The following is a description of a gene set: Rheumatoid arthritis Inflammatory changes in the synovial membranes and articular structures with widespread fibrinoid degeneration of the collagen fibers in mesenchymal tissues, as well as atrophy and rarefaction of bony structures. Human Gene Set: HP_RHEUMATOID_ARTHRITIS studied in species Homo sapiens, and this is the list of marker genes: CIITA, NFKBIL1, LACC1, IGKC, IL2RA, DCLRE1C, ACP5, HLA-DRB1, PTPN2, GCH1, SLC22A4, IL6 (interleukin 6, NCBI Gene Id 3569), IL10, CD247, PTPN22, MIF, NR4A2, IGHG2, IL2RB, ANKRD55, CD244, STAT4, IMPDH2